Given this list of marker genes RUVBL1, TAF9, NUFIP1, ZNHIT3, ZNHIT6, SHQ1, NAF1, SNU13, NOPCHAP1, PIH1D1, RUVBL2, PIH1D2, here is a description of the gene set: The aggregation, arrangement and bonding together of proteins and a snoRNA to form a small nucleolar ribonucleoprotein (snoRNP) complex. studied in species Homo sapiens Human Gene Set: GOBP_SMALL_NUCLEOLAR_RIBONUCLEOPROTEIN_COMPLEX_ASSEMBLY